The following is a description of a gene set: Visually assessable vertical indentation, cleft, or depression of the nasal bridge, ridge and tip. Human Gene Set: HP_BIFID_NOSE Bifid nose species: Homo sapiens, and this is the list of marker genes: NF1, ZSWIM6, TFE3, FREM1, ALX3, NSMF, ALX4, HYLS1, NUAK2, ALX1, TBX4, PTCH1